Given this list of marker genes ERBB2, EPHA4, NRP1, IL10RA, MUSK, FGFR4, ROR1, GRK1, ROR2, TIE1, EPHA7, IL3RA, PDGFRL, EFNB3, EPHB2 (EPH receptor B2), PDGFRB, PDGFRA, IL2RG, MAP2K7, CSF2RA, IL13RA1, EPHB6, IFNGR1, DDR2, CDKN1A, MAPK10, DAPK1 (NCBI Gene Id 1612), PTK7, MYLK, ERBB4, CSF3R, IL7R, EPHA2, MPL, MST1R, F3, EPHB1, EFNA4, CSF2RB, AXL, CCL2, TEK, IL2RB, MERTK, RYK, ROS1, BMPR1B, KIT, FGFR3, KDR, FGFR2, FGFR1, CDK5R1, LEPR (NCBI Gene Id 3953), IL4R, PDK4, GRK5, here is a description of the gene set: Human Gene Set: MODULE_199 species: Homo sapiens Genes in the cancer module 199.